Given this list of marker genes TUFT1, CXCL2, MBP, MMP24, NLRX1, SYT5 (synaptotagmin 5), STK11IP, GPR137B, NDUFA3, MAN2B1, ABCD1, PBX2, LTC4S, DNAJA1, BID, NR1H3, SAA1, PPP2R5A, CLASRP, SLC7A7, TINF2, CPT1A, NSMCE3, TCP11, GDI1, IPO4, SCAF8, ATP6V0B (NCBI Gene Id 533), TEN1, AGTRAP, HLA-DMB, STXBP2, GMCL1, S100A5, FGFR1OP2, CTCF, CCDC12, GRIA4, TDP2 (tyrosyl-DNA phosphodiesterase 2), PARN (NCBI Gene Id 5073), CDCA5, RASSF5, VRK1, CTPS2 (NCBI Gene Id 95807), ELOA, EIF2AK1, MED12L, COTL1, ARL6IP4, GSR, GATAD2A, DYM, CDK5RAP3, PUS1, EMB, INPP5K, CSTF1, TXNL4A, MRPL4, MRPS5, KCNAB1, ALG2, POLR2I, UBR7, ASCC1, CLCN7, ADAR, FBXO21, CIT, MEIG1, CHCHD3, MAD2L1BP, TMEM38B, FES, PRPS2, VAC14, TBP, MKNK1, PTPRJ, BCKDHA, RASA4, KCTD10, UBXN8, MC3R, RABGGTA, RAD23A, XRCC5, SPPL3, PRTN3, EIF3L, CALCB, SELPLG, PCBP2, KCNAB2, TRH, HAUS4, PPP5C, NPHP1, OMP, COQ3, RPF1, TGFB1, FZD7, CDKN2C, ACOX1, C1orf174, GNG12, HBB, ALDOA, ACHE, STAT6, HCK, POLD2, DALRD3, GCNT1, PEX2, PLEKHO1, MOS, H1-10, WDR77, UBE2T, TIE1 (tyrosine kinase with immunoglobulin like and EGF like domains 1), DBNDD2, ARHGDIB, PSTPIP1, AKAP8, FYTTD1, PARM1, FARS2, MIX23, MKRN1, GUK1, CDIP1, BCKDK, NMU, DDX41, RPL19, IL6, G6PD, NFATC1, LMAN2, CD82, ARHGEF1, PHB2, CHAF1B, PTPRO, SCN8A, HSPA1A, PGAP4, MRPS33 (NCBI Gene Id 65515), SWAP70, RPS18, PRM3, DHRS1, ARF1, CD34, COMMD4, ARFGAP3, FAF1, LTA4H, TMEM222, IL11, FUT9, CEBPD, FBXO9, F2RL3, RASD1, RASL11B, GJB4, SDHD, PRKCI, SMAD3, HES6, GAS6, FDPS, OAZ2, GGT5, FDX1, B3GALT4, TPGS1, CMTR2, RAB28, PRKCD, IER2, PLXND1, PSTPIP2, TAL2, MAP2K7, CCND3, EEF1B2 (NCBI Gene Id 1933), MAP4K1, MRPL46, FH, METTL18, MEPCE, RABGGTB, PACS1, PTPN20, TADA1, YJU2B, here is a description of the gene set: Genes up-regulated in CD4 T helper cells Th17 treated with TGFB1 and IL6: 1h versus 20h. from publication Yosef N, Shalek AK, Gaublomme JT, Jin H, Lee Y, Awasthi A, Wu C, Karwacz K, Xiao S, Jorgolli M, Gennert D, Satija R, Shakya A, Lu DY, Trombetta JJ, Pillai MR, Ratcliffe PJ, Coleman ML, Bix M, Tantin D, Park H, Kuchroo VK, Regev A (PMID 23467089) Human Gene Set: GSE43955_1H_VS_20H_ACT_CD4_TCELL_WITH_TGFB_IL6_UP Despite their enormous importance, the molecular circuits that control the differentiation of Th17 cells remain largely unknown. Recent studies have reconstructed regulatory networks in mammalian cells, but have focused on short-term responses and relied on perturbation approaches that cannot be applied to primary T cells. Here, we develop a systematic strategy – combining transcriptional profiling at high temporal resolution, novel computational algorithms, and innovative nanowire-based tools for performing gene perturbations in primary T cells – to derive and experimentally validate a temporal model of the dynamic regulatory network that controls Th17 differentiation. The network is arranged into two self-reinforcing and mutually antagonistic modules that either suppress or promote Th17 differentiation. The two modules contain 12 novel regulators with no previous implication in Th17 differentiation, which may be essential to maintain the appropriate balance of Th17 and other CD4+ T cell subsets. Overall, our study identifies and validates 39 regulatory factors that are embedded within a comprehensive temporal network and identifies novel drug targets and organizational principles for the differentiation of Th17 cells. studied in species Homo sapiens